Given this list of marker genes ZDHHC17, ANTXR2, PRSS27, PVALB, TAOK1, PDE4B, TMEM14C, ERCC3, FBXO3, QKI, SMAD4, KCNQ3 (potassium voltage-gated channel subfamily Q member 3), KCTD8, CAPRIN1, VAT1L, ZNF667, MTMR9, MRPS17, SH3GLB1, SYPL1, PCMTD1, TNPO1, ARPP19, EDNRB, EIF4A2, MDFIC, ZDHHC21, HECW2, VPS13C, TAF4B, SLC38A11, DGCR2, TMEM178A, PIK3CD, UBE2W, CTTNBP2, CAMSAP2, PLK4, DCUN1D5, CCNT2 (NCBI Gene Id 905), TRPC1, DCLRE1A, UBE2E3, NR3C1, RPS6KA6, COL4A3, BRINP3, NRCAM (neuronal cell adhesion molecule), PTPN2, RFX7, HACE1, TNF (NCBI Gene Id 7124), SYTL3, ATP6V1A, UIMC1, CBLN4, ITM2B, NRARP, TNFSF13B, FAM210A, ARL5A, ADCYAP1, GLS, JUN, AKAIN1, VPS37A, BTRC, UBN2, SEMA3C, EPC1, BNC2, CTPS1, TNIK, PI15, MTSS1, HHIP (hedgehog interacting protein), KMT5B, PPM1B, CC2D2B, BDNF, RCHY1, ZNF470, TRA2A, CCDC14, DSG1 (desmoglein 1), DYRK4, TMEM135, GNAI3, LEPROT, SMARCAD1, TMEM255A, MPPED2, DPY19L4, ACVR1C, FPGT-TNNI3K, IL1RAP, MACC1, CDK6, DAZAP1, UGCG, BEND4, NEFM (neurofilament medium chain), PPIG, C8orf76, SCML2, FAM91A1, EVI2B, SKP2, EPHX4, TTC14, PPP3CC, HNRNPH1, ZNF329, ZNF493, XIAP, FAM117B, LTBP1, FUS, SS18, OSBPL6, PIAS2 (NCBI Gene Id 9063), SMIM8, RNF43, RICTOR, TMSB4Y, ST8SIA4, EGR1, PAX6, RUFY4, APBB2, ASZ1, TRIL, BCL11A, TNFRSF17, FLVCR1, CREB1, POU3F1 (NCBI Gene Id 5453), REV1, NMNAT2, SLC30A6, IPMK, TTF2, PAPPA, SMAD7, ADSS2, TADA2B, FGD6 (FYVE, RhoGEF and PH domain containing 6), COL21A1, SIX4, SLC16A14, SCAF11, FAM114A1, VTA1, SDC2, ZNF280D, PDZD2, GTF2H2, TLNRD1, PHYHIPL, ZFAND6, GTPBP10, GLCCI1, PGM2, CDYL, ZMYM5, LMLN, ASAP2, ROBO2, HEATR5A, ASTN2 (astrotactin 2), RAB30, INO80D, ACSL3, CENPJ, LIMCH1, USP15, CADM2, ZNRF2 (NCBI Gene Id 223082), ADAMTS9, ATP6V1B1, TRDMT1, LEPROTL1, FGF7, ESYT2, ADAM22, NCAM1, APELA, FBXW11, LIFR, ATP2B1, HORMAD1, LIN9, MKX, DACH1 (NCBI Gene Id 1602), GTF2A1, ZNF217, TMEM170B, CHD1, POSTN, FOXJ3, FGFR1, PLS3, TOGARAM1, RBBP5, RBMX, GABRA4, SERPINB8 (serpin family B member 8), MOSPD1, NPAP1, MYT1, ZCCHC4, RPGRIP1L, ASAH1, TMEM33, UBE2V2, CHAC2, ZFP36L1, HOXC6, KLRC2, SP4 (Sp4 transcription factor), VEPH1 (ventricular zone expressed PH domain containing 1), ETNK1, HOOK3, DDHD1, F8, ACP3, CLEC6A, CAAP1, DERL3, CNOT8, TRIM23, IL12A, MEF2C, PAK3, CMSS1, SLC10A7, TMED2, PCDH19, ZNF503, TULP4 (NCBI Gene Id 56995), RECK, GPNMB, PHC1, SEMA7A, CREBBP, CFAP97, KIFBP, CRYBG3, XPNPEP3, PBX1, DENND5A, CAV2, DCT, FAAH2, NSMCE3, TNNI3K, PRTG (protogenin), OTUD6B (NCBI Gene Id 51633), OMA1, GSE1, ZNF492, L3MBTL3 (L3MBTL histone methyl-lysine binding protein 3), APPL1, PIGBOS1, ABCC4, TNFSF15, PRDM1, EMB, COL19A1, TMX2, SSBP2, DDIT4L, CSNK1G3, ARMC8, DOCK4, DNAJC21, PRRG1, ZC3H12C, PURG, FHIP1B, FGB, GDA, CCDC141, EIF2S3, KLHL28, FKBP6, ANGPT2, KLF11, AAK1, SPOCK3, RELN, NANP, CALHM4, HAUS6, JUND, TPTE, ZNF468, GRM1, PFN2, ZBTB20, ICE2, TNRC6B, ZBTB18, GAN, CEP170, TNC, ADGRL3, CKS1B, NRXN1, STK4, H2AZ2, NDUFAF4, USP37, UTP6, SNX29, ZIC3, N4BP1, C8orf44-SGK3, BRWD1, MIGA1, CDKN1B, LAMC1, JUP, SHISA3, BCL2L11, PRDM15, TANK, ARL2BP, RBM46, PRKCH, ADAMTS1, LRR1, C14orf39, RNLS, FBXL3, SLC4A7, REST, DNAJC16, ZNF25, MAPK7, BRD10, SON, CHL1, TIAM1, SGK3, PJA2, CDK17, PLPPR5, R3HDM1, CHRNA5, RETREG2, ZNF827, DEPDC1, BPNT2, ICA1L, ATP10A, SLC17A8, SCN1A, KHDRBS3, MAGEB6, MAN1A1, COL25A1, ZFP36L2, LUC7L, SOX8, PALM2AKAP2, WNT7B, SELE, MGST1 (NCBI Gene Id 4257), GLI3, TGFBR2, VPS13B, NCBP3, IQCH, LRP8 (NCBI Gene Id 7804), YWHAZ, MAP2K6, CSTF2T, SH3D19, ZNF320 (zinc finger protein 320), DDB2, TMEM165, BTN2A2, HBEGF, STRAP, GABPA, SLC25A36, MINDY3, LRP6, LRP12, NKX2-5, GIMAP6, TAF2, OBI1, TMEM260, TBL1X, CHIC1, CALCRL, CHAMP1, PHACTR2, COX15, MKRN3 (NCBI Gene Id 7681), HOXB2, UBE2H, ZNF678, NCAM2, EREG, ARAF, SLC7A11, SACS, ELK4, EIF3J, PYGO1, PAXIP1, BMP2K, GNAI1, NHLH2, PCGF3, PTGES3, ZFPM2, ROR2, CD109, MTMR6, MYO3B, DLG2, GATA2, ANKRD27, RGS4, AP1S3, GRID1, KLRC1, RAF1, FBXO33, GOLGA6C, RHEB, RMDN2, POU3F2, ACSM5, ZKSCAN4, ZEB1, LPCAT2, AGFG1, RAPGEF4, FGD4, CCDC28A, MMP3, GRAMD2B, GABRB3, ELAVL2, MON2, SH2D1B, ZNF529, GPM6A, SEMA5A, CALD1, IGFBP5, THAP10, ZMYND19, FRMPD4 (NCBI Gene Id 9758), here is a description of the gene set: species: Homo sapiens Genes predicted to be targets of miRBase v22 microRNA hsa-miR-4803 in miRDB v6.0 with MirTarget v4 prediction scores > 80 (high confidence targets). Human Gene Set: MIR4803 from publication Chen Y, Wang X (PMID 31504780)